Given this list of marker genes Ciao3, Ciao1, Ciao2b, Ciao2a, Mms19, here is a description of the gene set: studied in species Mus musculus A protein complex capable of condensing two 2Fe-2S clusters into one 4Fe-4S center in the cytoplasm and nucleus. In humans it consists of MMS19, CIAO1, CIAO2A/CIAO2B, CIAO3. MMS19, CIAO1 and CIAO2A/CIAO2B form a tight 'core' complex, whereas CIAO3 is an 'external' component of this complex. Mouse Gene Set: GOCC_CYTOSOLIC_4FE_4S_ASSEMBLY_TARGETING_COMPLEX